Given this list of marker genes TIMMDC1, MT-ND1 (mitochondrially encoded NADH:ubiquinone oxidoreductase core subunit 1), MT-CO1, TMEM126B, NDUFAF5, NDUFB10, NDUFAF3, NDUFAF8, AFG3L2, MT-TW, NUBPL, SDHA, NDUFAF2, NDUFAF1, MT-TS2, NDUFB9, MT-TH, MT-TF, MT-ND5, MT-TL1, NDUFS2, NDUFS1, MT-ND3, NDUFB3, NDUFA1, NDUFS3, MT-CO2, NDUFS4, MT-ATP6, FOXRED1, MT-ND6 (mitochondrially encoded NADH:ubiquinone oxidoreductase core subunit 6), NDUFB11, MT-ND4, MYH7, MT-ND2, NDUFA11, NDUFV2, MT-TL2, NDUFAF4, NDUFS6 (NCBI Gene Id 4726), NDUFV1, MT-CO3, NDUFS7, NDUFS8, MT-TN, NDUFA6, MT-TQ, here is a description of the gene set: studied in species Homo sapiens Human Gene Set: HP_ABNORMAL_MITOCHONDRIA_IN_MUSCLE_TISSUE An abnormality of the mitochondria in muscle tissue. Abnormal mitochondria in muscle tissue